Given this list of marker genes MAPRE3, NUMA1, KIF18B, MAPRE1, KIF18A, MISP (mitotic spindle positioning), DYNLT3, CCSAP (centriole, cilia and spindle associated protein), here is a description of the gene set: species: Homo sapiens Any of the mitotic spindle microtubules that radiate in all directions from the spindle poles and are thought to contribute to the forces that separate the poles and position them in relation to the rest of the cell. Human Gene Set: GOCC_MITOTIC_SPINDLE_ASTRAL_MICROTUBULE